Given this list of marker genes Snora62, Nop56, Rpp25l, Fbll1, Pop1, Snora68, Rpp30, Nop58, Naf1, Lsm6, Rpp25, Snora69, Rpp40, Pop5, Rpp38 (ribonuclease P/MRP 38 subunit), Snu13, Mphosph10, Dkc1, Snora70, Nolc1, Snora64, Fbl, Pop7, Rrp9, Gar1, Nop10, Nhp2, Pop4, Ins2 (NCBI Gene Id 16334), Snora65, here is a description of the gene set: studied in species Mus musculus A ribonucleoprotein complex that contains an RNA molecule of the snoRNA family and associated proteins. Many are involved in a step of processing of rRNA molecules: cleavage, 2'-O-methylation, or pseudouridylation, but other RNA types can be targets as well. The majority fall into one of two classes, box C/D type or box H/ACA type, which are conserved across eukaryotes and archaea. Other members include the telomerase RNA and the ribonuclease MRP RNA. Mouse Gene Set: GOCC_SNO_S_RNA_CONTAINING_RIBONUCLEOPROTEIN_COMPLEX